Given this list of marker genes MAN2B2, S100A12, L3MBTL1, CDR2, CDKL1, USP34, GDF10, ELANE, CEACAM6, GCHFR, FZD6, CTSL, LCN2, PIGA, MRE11, KIF3A, PRKCQ, CHD1L, RCC1, TCTN3, here is a description of the gene set: from publication Cheok MH, Yang W, Pui CH, Downing JR, Cheng C, Naeve CW, Relling MV, Evans WE (PMID 12704389) To elucidate the genomics of cellular responses to cancer treatment, we analyzed the expression of over 9,600 human genes in acute lymphoblastic leukemia cells before and after in vivo treatment with methotrexate and mercaptopurine given alone or in combination. Based on changes in gene expression, we identified genes that accurately discriminated among the four treatments. Discriminating genes included those involved in apoptosis, mismatch repair, cell cycle control and stress response. Only 14% of genes that changed when these medications were given as single agents also changed when they were given together. These data indicate that lymphoid leukemia cells of different molecular subtypes share common pathways of genomic response to the same treatment, that changes in gene expression are treatment-specific and that gene expression can illuminate differences in cellular response to drug combinations versus single agents. Human Gene Set: CHEOK_RESPONSE_TO_MERCAPTOPURINE_AND_LD_MTX_DN species: Homo sapiens Genes specifically down-regulated in pediatric acute lymphoblastic leukemia (ALL) patients by mercaptopurine and low-dose methotrexate (LDMTX).